The following is a description of a gene set: Mouse Gene Set: GOBP_NEGATIVE_REGULATION_OF_ACTIN_NUCLEATION studied in species Mus musculus Any process that stops, prevents, or reduces the frequency, rate or extent of actin nucleation, the initial step in the formation of an actin filament in which actin monomers combine to form a new filament., and this is the list of marker genes: Coro1a, Dnai3, Gmfg, Coro1b, Ctnna2, Hip1r, Pick1, Arpin, Gmfb